Given this list of marker genes INHBB, C4BPB, SLC2A1, SNX5, MAGEA2, CD55, here is a description of the gene set: from publication Rodrigues S, De Wever O, Bruyneel E, Rooney RJ, Gespach C (PMID 17334389) Human Gene Set: RODRIGUES_DCC_TARGETS_UP species: Homo sapiens Genes up-regulated in HCT8/S1 cells (colon cancer) which normally lack DCC compared to those stably expressing wild type DCC off a plasmid vector. Deleted in colon cancer (DCC) and UNC5 function as netrin dependence receptors by inducing apoptosis in the absence of their ligand and accordingly were recently designated as putative conditional tumor suppressors. Herein, we determined whether netrin-1 and its receptors are implicated in cancer cell invasion and tumor progression. Expression of DCC, UNC5 and adenosine A2B-receptors (A2B-Rs) was investigated by reverse transcription polymerase chain reaction in human colon cancer cells. The impact of DCC restitution and netrin-1 was evaluated on collagen type I invasion, tumor growth and metastasis in nude mice, cancer cell survival and gene expression profiling. Flow cytometry, poly(ADP-ribose)polymerase-1 and caspase-8 activation were used to evaluate the impact of DCC on cell death. Both netrin-1 and A2B-R activation induced the invasive phenotype through the Rho-Rho kinase axis in DCC-deficient human colorectal cancer cells. Restitution of wild-type DCC blocked invasion induced by netrin-1, A2B-R agonist and other agents. Ectopic expression of netrin-1 led to increased growth of human colon tumor xenografts in athymic mice. Conversely, introduction of wt-DCC in kidney MDCKts.src-ggl cells strongly inhibited metastasis in lymph nodes and lungs and increased sensitivity to apoptosis in hypoxia. DNA microarrays revealed that netrin and DCC had common and divergent impacts on gene expression linked to cell cycle, survival, surface signaling and adhesion. Our findings underscore that netrin is a potent invasion and tumor growth-promoting agent and that DCC is a metastasis suppressor gene targeting both proinvasive and survival pathways in a cumulative manner.